The following is a description of a gene set: studied in species Homo sapiens Human Gene Set: chr1q24, and this is the list of marker genes: ENSG00000230704, MIR214, TBX19, LINC01675, TMCO1, RPL7AP21, MROH9, ENSG00000294810, GCSHP5, SELP, VAMP4, MIR3120, SIGLEC30P (sialic acid binding Ig like lectin 30, pseudogene), ADCY10, MPZL1, FASLG, SLC19A2, SELE, FIRRM, ENSG00000227907, SUMO1P2, FMO1, CREG1, DNM3, MIR1295B, DCAF6, RNA5SP65, FMO8P, POU2F1, TIPRL, METTL13, FMO3, KIFAP3, FMO10P, LINC00626, MIR3658, LRRC52, MYOC, LINC01363, PIGC, ENSG00000229588, RNU6-1310P, CCDC181, RPL34P1, ILDR2, FAM78B, F5, DNM3OS, STYXL2, PRRX1, FMO2 (flavin containing dimethylaniline monoxygenase 2), GM2AP2, MYOCOS, SELL, QRSL1P1, MIR3119-2, ALDH9A1, ISCUP1, ENSG00000237707, MAEL, FMO9P, DNM3-IT1, LRRC52-AS1, AKR1D1P1, LINC01142, METTL18, TOP1P1 (NCBI Gene Id 92224), DUTP6, RPL21P27, MIR921, ENSG00000293132, MIR199A2, RN7SL333P, RPL4P2 (NCBI Gene Id 646688), FMO4, HMGB1P11, C1orf105 (chromosome 1 open reading frame 105), ENSG00000228697, MPC2, MRPS10P1, DPT, UCK2, BLZF1, ENSG00000231424 (NCBI Gene Id 105371611), RPL29P7, POGK, RPS3AP10, ATP1B1, XCL1, FMO7P, RCSD1, SCYL3, RN7SL269P, KIFAP3-AS1, MIR1255B2, RPL7AP19, GORAB-AS1, MIR3119-1, RNA5SP64, FMO6P, FMO11P, RNU6-693P (NCBI Gene Id 106481399), LINC01681, XCL2, LINC00970, RNA5SP66, MIR557, GORAB, POU2F1-DT, CD247, TADA1, PRRC2C, SUCO, NME7, MIR1295A, RPL4P3, CYCSP53, SLC25A38P1, MGST3 (microsomal glutathione S-transferase 3), FAM78B-AS1, SFT2D2, PFN1P1, GPR161, SRP14P4, RNU6-157P, TMCO1-AS1, AIMP1P2, HAUS4P1, ANKRD36BP1, CNN2P10, NTMT2, GPA33 (glycoprotein A33)